Given this list of marker genes Olfm1, Zfpm2, Zfpm1, Gata4, Notch1, Smad4, Hey2, Hey1, Dchs1, here is a description of the gene set: The developmental process pertaining to the initial formation of the atrioventricular valve from unspecified parts. This process begins with the specific processes that contribute to the appearance of the discrete structure and ends when the structural rudiment is recognizable. studied in species Mus musculus Mouse Gene Set: GOBP_ATRIOVENTRICULAR_VALVE_FORMATION